The following is a description of a gene set: This event has been computationally inferred from an event that has been demonstrated in another species.<p>The inference is based on the homology mapping from PANTHER. Briefly, reactions for which all involved PhysicalEntities (in input, output and catalyst) have a mapped orthologue/paralogue (for complexes at least 75% of components must have a mapping) are inferred to the other species. electronically inferred by orthology from the curated human pathway Reactome Pathway: Trafficking and processing of endosomal TLR part of: Toll-like Receptor Cascades species: Mus musculus, and this is the list of marker genes: Tlr9, Lgmn, Unc93b1, Hsp90b1 (heat shock protein 90, beta (Grp94), member 1), Ctss, Tlr7, Tlr8